Given this list of marker genes Pdcd6ip, Bmf, Tgfb1, Bcl2l11, Polb, Trib3, Tnfaip3, Sh3glb1, Cd40, Bcl6, here is a description of the gene set: Mouse Gene Set: RAMJAUN_APOPTOSIS_BY_TGFB1_VIA_SMAD4_UP from publication Ramjaun AR, Tomlinson S, Eddaoudi A, Downward J (PMID 16909112) Apoptotic genes dependent on SMAD4 and up-regulated in AML12 cells (hepatocytes) after stimulation with TGFB1. studied in species Mus musculus Transforming growth factor-beta (TGFbeta)-activated signalling pathways can lead to apoptosis, growth arrest or promotion of malignant behaviour, dependent on cellular context. The molecular mechanisms involved in TGFbeta-induced apoptosis remain controversial; although changes in gene expression are thought to be pivotal to the process, several different candidate apoptotic initiators and mediators have been proposed. Smad4, a critical component of the TGFbeta-induced transcriptional machinery, is shown here to be essential for induction of apoptosis. Gene expression analysis identified the proapoptotic Bcl-2 family members, Bmf and Bim, as induced by TGFbeta, dependent on both Smad4 and p38 function and the generation of reactive oxygen species. TGFbeta-induced Bmf and Bim localize to cellular membranes implicated in apoptosis. Inhibition of the TGFbeta-induced expression of both these proteins together provides significant protection of cells from apoptosis. The TGFbeta-triggered cell death programme thus involves induction of multiple BH3-only proteins during the induction of apoptosis.